Given this list of marker genes SLC2A5, NPC1L1, RSC1A1, SLC5A1, SLC2A2, here is a description of the gene set: Human Gene Set: REACTOME_INTESTINAL_ABSORPTION Intestinal absorption species: Homo sapiens